Given this list of marker genes Cnih3, Dok7, Traf6, Tmem108, C1ql2, Vwc2, Gpc4, Hras, Agrn, Gphn (gephyrin), Nptxr, Dlg2, Rapgef4, Cacna2d2, Gpsm2, Vps26b, Lhfpl4, Nbea, Neto1, Kalrn (NCBI Gene Id 72378), Adam22, Cacng3, Tnik, Camk2a, Gsk3b, Git1, Nptx1, C1ql3, Musk, Kif2c, Ghsr, Gabarap, Rap1a (NCBI Gene Id 99734), Lgi1, Iqsec2, Dlg4, Magi2, Nptx2, Cacng2, Adam10, Olfm2, Nrxn3, Dlg1, Erbb4, Gpc6, Neto2, Ogt, Cacng7, Prkcz, Rapsn, Erbb2, Dag1, Map2k1, here is a description of the gene set: species: Mus musculus Mouse Gene Set: GOBP_NEUROTRANSMITTER_RECEPTOR_LOCALIZATION_TO_POSTSYNAPTIC_SPECIALIZATION_MEMBRANE A process in which a neurotransmitter is transported to, or maintained in, a location within the membrane adjacent to a postsynaptic specialization (e.g. postsynaptic density).